The following is a description of a gene set: The cleavage of a peptide bond in a precursor form of a signaling receptor ligand, resulting in the mature (active) form of the ligand. Human Gene Set: GOBP_SIGNALING_RECEPTOR_LIGAND_PRECURSOR_PROCESSING studied in species Homo sapiens, and this is the list of marker genes: FURIN, PLA2G7, CPA3, CTSG, BACE2, PCSK7, BACE1, ECE1, MBOAT4, SLC30A8, HID1, SCG5 (secretogranin V), ACE2, ACE, CORIN, CTSZ, ERO1B, CASP1, REN, YIPF5, MEP1A, PCSK5, ATP6AP2, SLC30A5, PCSK4, ECE2, MME, PCSK1, ADAM10, PREP, CPE, PCSK1N, DPP4, CTSL, CMA1, P4HB, PRCP, DISP1, CSTL1, PCSK6, ENPEP, PCSK2, BCHE, ANPEP, ADAM17